The following is a description of a gene set: studied in species Homo sapiens Human Gene Set: GOBP_PRODUCTION_OF_MOLECULAR_MEDIATOR_INVOLVED_IN_INFLAMMATORY_RESPONSE The synthesis or release of any molecular mediator of the inflammatory response following an inflammatory stimulus, resulting in an increase in its intracellular or extracellular levels., and this is the list of marker genes: IL17RA (NCBI Gene Id 23765, interleukin 17 receptor A), SYK, MIR378A, MIR125A, TLR4, LIPA, MIR338, LYN, CD6, MIR21, NOD2, LEP, PER1, NCF1, APPL2, TICAM1, LBP (NCBI Gene Id 3929), PRKCA, EPHB2, MIR98, PLD3, GBP5, IL1R2, PLA2G10, SNX6, HIF1A, MIR140, IL17F, GPSM3, PLA2G3, INS, SLC18A2, VAMP2, ALOX5AP, HMOX1, NLRP7, MIR221, RAB44, MEFV, CLEC7A, SIRPA, BAP1, MAPK14, PDCD4, IL17RC, MIR324, IKBKB, DUSP10, IL4R, EZH2, TREM2, LILRB4, NFKB1, P2RX1, MAPK9, PBXIP1, ZFP36, MIR26A1, MIR16-1, PSG9, F2, IL17D (interleukin 17D), IL6, FCER1G, PRDX2, FADS2 (fatty acid desaturase 2), BTK, TLR6, VAMP7, CHID1, GRN, NFKBIA, MYD88, MIR197, MIR136, MACIR, MIR135A1, VAMP8, IL17A, CUEDC2, MIR129-1, CHIA, CD36, SLAMF8, PYCARD, APPL1, NLRC3, MIR17, SERPINE1, ADAM17, PLD4, ABCD2 (ATP binding cassette subfamily D member 2), NOS2, APOD, JAK2, RELA, SPINK7, STAT3, PPARA, ABCD1, MIR222, TLR3, MIR93, IRF3, RPS19, IL17B, TNF, SNAP23, CHRNA7, VAMP3, SNX4, ZC3H12A, ALOX5, S100A9, MIR146A, ADCY7, CARD9, EXTL3, MIR203A, MIR675, KPNA6